The following is a description of a gene set: FOXP3 in COVID-19 Human Gene Set: WP_FOXP3_IN_COVID19 studied in species Homo sapiens, and this is the list of marker genes: IL2RB, CD28, IL6R, IL2RG, CD80, STAT3, FOXP3, IL6, IL6ST, STAT5B, IL2RA, IL7R, STAT5A, IL2, CD86 (NCBI Gene Id 942)